Given this list of marker genes Trpc3, Col14a1, Akap1, Rock1, Gsk3a, Pdlim5, Edn1, Bmp2, Prkg1, Smad4, Hamp, Nppa (NCBI Gene Id 230899), Nppb, Mef2c, Pin1rt1, Kcnn4, Bmp10 (bone morphogenetic protein 10), Becn1, Sorbs2, Stub1, P2rx4, Ctdp1, Lmna, Dyrk1a, Klf15, Pak1, Adk, Rgs2, Myoc, Sirt1, Gsn, Mstn, Adrb1, Jarid2, Mef2a, Adcy10, Pde5a, Ang2, Bmp4, Mymk, Tiam1, Adra1b, Ep300, Yy1, Ppara, Gata5, Gdf1, Ccn4, Cav3, Akap6, Ar, Adra1a, Parp2, Trip10, Ppp3ca, Tcap, Fbxo32, Acacb, Pak2 (NCBI Gene Id 77101), Nfatc3 (nuclear factor of activated T cells, cytoplasmic, calcineurin dependent 3, NCBI Gene Id 97460), Rbm10, Hey2, Smad3, Mlip, G6pdx, Foxp1, Agtr2, Tnfrsf1b, Pparg, Myh7 (myosin, heavy polypeptide 7, cardiac muscle, beta), Rgs4, Twf1, Ezh2, Gata6, Tomm70a, Rap1gds1, Cyba, Inpp5f, Htr2b, Ttn, Gsk3b, Zfp418, Nr3c1, Prkca, Hand2, Ddx39b, Camta2, Cdk9, Ryr2, Mtpn, Fdps, Chaer1, Myocd, Atp2a2, Gata4, Akap13, Lep, Slc9a1, Mir208b, Parp1, Rock2, Pi16, Map2k4, Mtor, Camk2d, Kdm4a, Igf1, Smad1, Glrx3, Meis1, Myh6, Nr4a3, Ece1, Lmcd1 (LIM and cysteine-rich domains 1), Agt, Foxo1, Slc25a4, Trim63, Tnfrsf1a, Pin1, Notch1, Atp2b4, Errfi1, Csrp3, Igfbp5 (insulin-like growth factor binding protein 5), Hamp2, G6pd2 (NCBI Gene Id 14382, glucose-6-phosphate dehydrogenase 2), Ptk2, Pde9a, here is a description of the gene set: The muscle system process that results in enlargement or overgrowth of all or part of a muscle organ due to an increase in the size of its muscle cells. Physiological hypertrophy is a normal process during development (it stops in cardiac muscle after adolescence) and can also be brought on in response to demand. In athletes cardiac and skeletal muscles undergo hypertrophy stimulated by increasing muscle activity on exercise. Smooth muscle cells in the uterus undergo hypertrophy during pregnancy. Mouse Gene Set: GOBP_MUSCLE_HYPERTROPHY species: Mus musculus